Given this list of marker genes ENAM, TECRL, GNRHR, UGT2B15, IFITM3P1, UGT2B7, UGT2B10, TMPRSS11F (NCBI Gene Id 389208), GRSF1, AMBN, RNU6-784P, EXOC5P1, SYT14P1, MIR1269A, PPBPP1, MTND6P16, STAP1, UGT2A3P7, UGT2B28, BTC, SPOPLP3, EREG, ST3GAL1P1, PPBPP2, LDHAL6EP, EPHA5, UGT2B26P, SNORA62, RPS23P3, MUC7, AFP, DCK, PPBP, UBA6-DT, MTND3P24, UGT2B24P, ANKRD17, PARM1, EFL1P2, ENSG00000303699 (novel transcript, antisense to ANKRD17), RNU6-520P, STATH, MTCO3P28, CXCL1, TMPRSS11B, CXCL2, GC, SULT1B1, UGT2B4, ENSG00000251339, AMTN, ANKRD17-DT, TMPRSS11A, RPL17P19, SMR3A, SPOPLP2, TMPRSS11D, LINC02562, HTN3, MTHFD2L, CXCL6, RNU1-63P, MTND2P41, FTLP10 (ferritin light chain pseudogene 10), CXCL8, RPL6P10, MTCYBP16, ENSG00000250075, LINC02271, LINC02429, JCHAIN, CSN1S2AP, SLC4A4, RNU6-95P, UGT2B17, UGT2B11, UGT2B29P, RPS15AP17, YTHDC1, CABS1, UMLILO, TMPRSS11BNL, MTND4LP31, RNU6-191P, UGT2B25P, CSN3, PRR27, ADAMTS3, LINC02835, UGT2A3, ODAM, COX18, PF4, ADGRL3-AS1, TMPRSS11CP, RNA5SP163, HNRNPA1P67 (heterogeneous nuclear ribonucleoprotein A1 pseudogene 67), EPGN, LINC02494, MTCO3P27, RN7SL218P, POLR2MP1, LINC02232, OPRPN, FDCSP, RNU6-699P, UGT2A1, ALB, EPHA5-AS1, CXCL5, RNU4ATAC9P, RNU6ATAC5P, PARM1-AS1, RNU6-891P, HTN1, CSN2 (NCBI Gene Id 1447), RNU6-1325P, MIR548AG1, ENSG00000288659, RNA5SP527, RPL21P47, MTND5P13, LARP1BP1, NPFFR2, SULT1E1, ENSG00000221639, UTP3, HNRNPA1P55, CXCL1P1, MT2P1, HSPE1P23, RUFY3, SMR3B, HMGA1P2, AFM, PF4V1, CXCL3, INKILN, SULT1D1P, ENSG00000286848, ENSG00000248479, CENPC, UGT2B27P, MOB1B, LINC02496, ENSG00000304732 (novel transcript, antisense to EREG and MTHFD2L and EPGN), UBA6, RASSF6, SPOPLP1, LINC02619, LINC02499, TMPRSS11GP, ADGRL3, HMGN1P11, UGT2A2, AREG, TMPRSS11E, APOOP4, CSN1S1, RNU2-40P, DPP3P1, here is a description of the gene set: studied in species Homo sapiens Human Gene Set: chr4q13